The following is a description of a gene set: species: Homo sapiens part of: Retinoid cycle disease events Reactome Pathway: Defective visual phototransduction due to STRA6 loss of function Defects in STRA6 cause microphthalmia syndromic type 9 (MCOPS9, Matthew-Wood syndrome or Spear syndrome; MIM:601186). Mutiple systems are affected by this fatal syndrome including occular and cardiac abnormalities. Microphthalmia (also called microphthalmos, nanophthalmia or nanophthalmos) is a developmental disorder of the eye that literally means small eye and in most cases results in blindness., and this is the list of marker genes: TTR, STRA6, RBP4